The following is a description of a gene set: Human Gene Set: KEGG_MEDICUS_VARIANT_MUTATION_INACTIVATED_PRKAR1A_TO_ACTH_CORTISOL_SIGNALING_PATHWAY Pathway Definition from KEGG: (PRKAR1A*+PRKACA) -> (NR5A1,NR4A1,SP1,PBX1,CREB) => (STAR,CYP11B1) -> Cortisol studied in species Homo sapiens Mutation-inactivated PRKAR1A to ACTH-cortisol signaling pathway. Pathway ID: N00322. Pathway type: Variant. Pathway class: nt06360 Cushing syndrome., and this is the list of marker genes: CREB3L1, NR4A1, CREB5, PRKACA, ATF4, NR5A1 (NCBI Gene Id 2516), PBX1, CREB1, CREB3L4, PRKAR1A, CYP11B1, SP1, STAR, ATF2, CREB3, CREB3L3, ATF6B, CREB3L2